Given this list of marker genes MKKS, MIR214, ASB2, FLII, MYADM, LMOD1, LMOD3, ARFGEF1, KANK2, PRKCD, HIP1R, SLIT2, ADD1, SPTBN5, CYRIB, SPTBN2, SPTB, TRIOBP, AVIL, KANK3, LMOD2, VIL1, CRACD, BBS4, SVIL, TWF2, WASHC2C, TMSB4X, TMOD4, PFN2, CAPZA1, ADD2, SCIN, CAPZA3, TMOD2, CFL1, CARMIL2, SSH1, KANK4, SSH2, SPTBN4, EPS8, DMTN, SPTBN1, ADD3, PFN1, TMOD3, CAPZB, VILL, GSN, TWF1, RDX, KANK1, CAPG, TMOD1, CARMIL1, SPTAN1, CAPZA2 (NCBI Gene Id 830), SPTA1, MTPN, SSH3, here is a description of the gene set: species: Homo sapiens Human Gene Set: GOBP_NEGATIVE_REGULATION_OF_ACTIN_FILAMENT_POLYMERIZATION Any process that stops, prevents, or reduces the frequency, rate or extent of actin polymerization.